Given this list of marker genes CITED2, C12orf75, ARC (NCBI Gene Id 53837), CNIH1, TBL3, NHP2, KLF10, HM13, CCR4, OSBPL3, ECHDC1, FAM110A, MRPL50, CRIP1, IPO9, RNPC3, SELENOH, NAA20, DENND5A, P4HA2, TTC16, MYO1F, B3GNT5, SQLE, PLAGL1, CD27 (CD27 molecule), BAK1, SND1, TIMM8A, NOP16, PRPF18, SMCO4, HSPD1, CYB5B, SRM, IL1R1, FRMD4B, ALDH7A1, TMEM256, C1QBP, PAFAH1B2, TRAK2, PSMA6, CLYBL, PTRH1 (NCBI Gene Id 138428), GNPTG, CPEB1, UTP4, MATK, CD68, CPSF2, POR (NCBI Gene Id 96440), PPIL1, MRTO4 (MRT4 homolog, ribosome maturation factor), TMEM208, ACSL3, LGALS3, NEIL3, CDKN1A, PLEKHG3, PSMC2, TUBB2A, YARS2, ICAM1, PIMREG, CD22, GADD45B, ANXA3, PDCD6IP, RNF125, C15orf39, CFAP298, SMIM11, IPMK, TMEM121, FKBP5, NIBAN3, TOX2, LRRC59, SPEF1, NOLC1, AKAP1, UXT, UFM1, PFN1, POU2AF1, BCL7A (BAF chromatin remodeling complex subunit BCL7A), TFDP1, SLC16A1, EMP1, CTSV, SHE, CISD1, HMGA1, MED31, RNF157, AEN, ZC2HC1A, THOP1, SURF4, OXSR1, STX11, GET3, COX16, POP5, IL22, SDF2L1, PSMB5, CENPV, KSR1, AXIN2, CTPS1, MTA2, TEC, SYTL2, AHCY, ITGA7, PPP1R14C, KCNK5, TSPAN4, KIF22, EPDR1, CEBPA, SAP30, BCL3, ALG8, ATP5PO, GLYCTK, RNASE4, RPS27L, PIPOX, GALE, MRPS33, CDC20, NMRAL1, SNRPA1, EIF4EBP1, MPZL1 (myelin protein zero like 1), JDP2, ICA1L, SLC25A4, DHCR24, INPP5D, TNPO2, CXCR5, SC5D, GPRIN3, RYK, FAS, LMO4, UQCC1, FABP5, CISD3, HMGCR, BARD1, NME2, SNRNP40, GRPEL2, RYR1, COX17, IDI1, MRPL36, TIMM23, GALNT2 (polypeptide N-acetylgalactosaminyltransferase 2), TTC39C, MRPS28, SNRPD1, ZNF770, NIFK, DTX1 (NCBI Gene Id 1840), ZMIZ2, LAMTOR3, IRF8, SLC16A5, UHRF1, LDLR, NUCB2, SEC14L1, MACIR, DEPDC1, AP1S3, TG, ATP5MC1, CHAC2, BAHD1, FOCAD, CISH, RWDD1, PAICS (phosphoribosylaminoimidazole carboxylase and phosphoribosylaminoimidazolesuccinocarboxamide synthase), ASNS, TCF7, SYTL3, BATF, UCK2, CTSZ, HDAC8, ABCF2, NAF1, GSR, CHCHD4, here is a description of the gene set: studied in species Homo sapiens Human Gene Set: GSE37532_TREG_VS_TCONV_PPARG_KO_CD4_TCELL_FROM_VISCERAL_ADIPOSE_TISSUE_UP Genes up-regulated in visceral adipose tissue from aged PPARG knockout mice: T reg versus T conv. We identified Pparg as a major orchestrator of the phenotype of adipose-tissue resident regulatory T cells (VAT Tregs). To establish the role of Pparg in shaping the VAT Tregs gene profile and cell dynamics, Tregs from lymph nodes and visceral adipose tissue of mice sufficient and deficient of Pparg expression in Tregs were double sorted for microarray analysis. from publication Cipolletta D, Feuerer M, Li A, Kamei N, Lee J, Shoelson SE, Benoist C, Mathis D (PMID 22722857)